The following is a description of a gene set: Mouse Gene Set: chr6F3 species: Mus musculus, and this is the list of marker genes: Gm8774, Gm8778, Klra2, Gm28809, Gm8724, Klra5, Ntf3, Klrb1-ps1, Gm20997, Gm10069, Tmem52b, Gm29788, 9330179D12Rik, Klra17, Clec2j, Gm18688, Tas2r114, Gm10010, Clec2h, Klra10, Klri2, Klrc2, Klra11-ps, Pzp, 9330102E08Rik, Gm53052, Gm21940, Gm6600, Gm7308, Gm8719, Clec12a, Klra8, Gm5582, 2310001H17Rik, Gm18423, Styk1, Gm4968, Clec7a, 1700101I11Rik, Gm43631, Klra9, Clec2g, Tulp3, Clec1a, 5430401F13Rik, Klrd1, Klri1, Gm33320, Gm53051, Gm15870, Gm6590, Tas2r107, Klrb1a, Gm8837, Gm19065, Gm8816 (NCBI Gene Id 667793), Tigar, Tnfrsf1a, Gm44134, Clec2f, Scnn1a, Kcna1, Gm6584, Gm24947, Klra6, Clec2i, Dyrk4, Gm5884, Gm44066, Gm43975 (predicted gene, 43975), Akap3, Clec2m, Foxm1, Ccnd2, Tead4, Gm44150, A2ml1, Gm26728, Gm15987, Fgf6, Gm15854, Gm4736, Gm34091, Klrc3, Tas2r104, Tuba3a, Klra1, Mir680-1, Clec9a, Hmgb1l, Gm43125, Klrc1, Klra14-ps, Klrb1 (killer cell lectin-like receptor subfamily B member 1), Gm10415, Tspan9, Ybx3, Gm8703, BC035044, Klrb1b, Gm4691, Tas2r106, Gm42458, Rpl18-ps2, Gm26160, Gm18609, Klra13-ps, Tpi-rs11, Nrip2, Fgf23, Gm18995, Gm6619, Stambp-ps1 (NCBI Gene Id 100416267), Tex52, Prmt8, Gm44431, Ano2, Gm5581, Fkbp4, Gm38901, Mir7233, Gm38404, Klrh1, Vwf (NCBI Gene Id 330420), Klre1, Itfg2, Clec2e, Cd9, Prb3-ps, Ndufa9, Kcna5, Rad51ap1, Gm22362, Klra4, Cracr2a, Kcna6, Parp11, Tspan11, Gm24072, Cd69, Olr1, Rhno1, Gm44478, Klrb1c, Gm43124, Gm17808, Tas2r130, Gm53286, BC064078, Gabarapl1, Klra7, Klra3, Clec1b, Plekhg6, Klrk1, Gm27047, D6Wsu163e, 4921513H07Rik, Magohb, Tas2r105, Gm5318, Clec2d, Ltbr, Klrb1f, Gm7309, 1700018A23Rik, Clec12b